Given this list of marker genes UMPS, HPRT1, ADA, GMPS, ADK, IMPDH2, PAICS, TYMS, APRT, GART, here is a description of the gene set: Human Gene Set: MODULE_21 species: Homo sapiens Genes in the cancer module 21.